Given this list of marker genes HNRNPA1, DAXX, NEFL, HSF1, ZC3H12A, MAPK13, here is a description of the gene set: studied in species Homo sapiens Any process that results in a change in state or activity of a cell or an organism (in terms of movement, secretion, enzyme production, gene expression, etc.) as a result of a sodium arsenite stimulus. Human Gene Set: GOBP_RESPONSE_TO_SODIUM_ARSENITE